The following is a description of a gene set: studied in species Homo sapiens Reactome Pathway: Anchoring fibril formation part of: Assembly of collagen fibrils and other multimeric structures Collagen VII forms anchoring fibrils, composed of antiparallel dimers that connect the dermis to the epidermis. During fibrillogenesis, the nascent type VII procollagen molecules dimerize in an antiparallel manner. The C-propeptide is then removed by Bone morphogenetic protein 1 and the processed antiparallel dimers laterally aggregate., and this is the list of marker genes: COL7A1, TLL2, COL4A4, COL1A2, COL4A3, LAMC2, COL4A6, TLL1, COL1A1, LAMB3, COL4A5, BMP1, COL4A2, COL4A1, LAMA3